Given this list of marker genes Scamp2, Lrrc8d, Peli1, Zfp746, Cyb561d2, Pip4p1, Zrsr2, Ighm, Plcb3, P2ry13, Spic, here is a description of the gene set: Cytokines mediate cell-cell communication in the immune system and represent important therapeutic targets. A myriad of studies have highlighted their central role in immune function, yet we lack a global view of the cellular responses of each immune cell type to each cytokine. To address this gap, the authors created the Immune Dictionary, a compendium of single-cell transcriptomic profiles of more than 17 immune cell types in response to each of 86 cytokines (>1,400 cytokine-cell type combinations) in mouse lymph nodes in vivo. A cytokine-centric view of the dictionary revealed that most cytokines induce highly cell-type-specific responses. For example, the inflammatory cytokine interleukin-1β induces distinct gene programmes in almost every cell type. A cell-type-centric view of the dictionary identified more than 66 cytokine-driven cellular polarization states across immune cell types, including previously uncharacterized states such as an interleukin-18-induced polyfunctional natural killer cell state. studied in species Mus musculus Genes positively differentially expressed in cell type: Macrophage upon treatment with cytokine: IL-36Ra in mouse lymph nodes in vivo. from publication Cui A, Huang T, Li S, Ma A, Pérez JL, Sander C, Keskin DB, Wu CJ, Fraenkel E, Hacohen N (PMID 38057668) Mouse Gene Set: CUI_MACROPHAGE_IL36RA_RESPONSE_UP